Given this list of marker genes STK39, SCT, WNK3, WNK4, CEL, COPA, AQP1, NR1H2, WNK1, NR1H3, AQP5, here is a description of the gene set: studied in species Homo sapiens The regulated release of pancreatic juice by the exocrine pancreas into the upper part of the intestine. Pancreatic juice is slightly alkaline and contains numerous enzymes and inactive enzyme precursors including alpha-amylase, chymotrypsinogen, lipase, procarboxypeptidase, proelastase, prophospholipase A2, ribonuclease, and trypsinogen. Its high concentration of bicarbonate ions helps to neutralize the acid from the stomach. Human Gene Set: GOBP_PANCREATIC_JUICE_SECRETION